Given this list of marker genes SLC2A1, SMARCE1, SMARCD1, ANTXR1, ARID1A, CCNK, ABCA5, KCNH1, AP2M1, EXT1, RAD21, SOX4, SMARCC2, SMARCA4, SYNGAP1, SMARCB1, KANSL1, ZSWIM6, NF1, ARSL, CHD2, SCN1A, AKT1, H4C5, ARID2, DPF2, ANKRD17, ARID1B, PIK3C2A, TRPS1, SOX11, RPS6KA3, NEXMIF, SCNM1, SLC6A1, MED12, RHOA, SMARCA2, here is a description of the gene set: Increase in bulk of the ala nasi. studied in species Homo sapiens Human Gene Set: HP_THICK_NASAL_ALAE Thick nasal alae